Given this list of marker genes Usp36, Rab14, Pds5b, 1810055G02Rik, Dlg3, Fnip2, Bloc1s4, Trib2, Rps6kb1, Nsg1, Plxnc1, Herc2, Ap2b1, Prickle1, here is a description of the gene set: species: Mus musculus Genes predicted to be targets of miRBase v22 microRNA mmu_miR_6959_3p in miRDB v6.0 with MirTarget v4 prediction scores > 80 (high confidence targets). from publication Chen Y, Wang X (PMID 31504780) Mouse Gene Set: MIR_6959_3P